Given this list of marker genes Csf1r, Lif (NCBI Gene Id 16878), Serpine2, Mag, Hes1, Id2, Bmp2, Actr3, Clcf1, Prpf19, Il1b, Bin1, Shh, Il6st, Notch1, here is a description of the gene set: studied in species Mus musculus Any process that activates or increases the frequency, rate or extent of astrocyte differentiation. Mouse Gene Set: GOBP_POSITIVE_REGULATION_OF_ASTROCYTE_DIFFERENTIATION